Given this list of marker genes LONP2, CLPX, LONP1, AFG3L2, SPG7, CLPP, YME1L1 (YME1 like 1 ATPase, NCBI Gene Id 115724), here is a description of the gene set: Catalysis of the hydrolysis of peptide bonds, driven by ATP hydrolysis. studied in species Homo sapiens Human Gene Set: GOMF_ATP_DEPENDENT_PEPTIDASE_ACTIVITY